Given this list of marker genes GP9, GP1BB, FLNA, GP5, GP1BA, here is a description of the gene set: Human Gene Set: GOCC_GLYCOPROTEIN_IB_IX_V_COMPLEX A transmembrane signaling receptor complex found exclusively on platelets. Involved in haemostasis and thrombosis where it aids blood coagulation. species: Homo sapiens